The following is a description of a gene set: from publication Yevshin I, Sharipov R, Kolmykov S, Kondrakhin Y, Kolpakov F (PMID 30445619) studied in species Mus musculus Mouse Gene Set: ZFP986_UNIPROT_L7MUC9_UNREVIEWED_TARGET_GENES, and this is the list of marker genes: Atp6v0a1, Or6n1, Ncor1, Ctbp2, Slc38a8, Rnf115, Gm11637, Myo15a, Cltc, Gm15895, Alg11, Dnajc11, Ppp4r1, Gm12608, Fh1, Ercc2, Dync1h1, Gm2990, Fuca1, 2900079G21Rik, Niban3, Fam81a, Gm19705, Kcnj16 (NCBI Gene Id 338361), Ccdc14, Prpf38b, Gstp2, Krtap20-2, Tbl3, Gm26049, Inpp5k, Serpine2, Emc8, Myom3 (NCBI Gene Id 433768), Fam193b, Slc18a3, Gm11444, Ufsp2, Erg, Nvl, Aste1, Rph3a, Gm26795, Crem, Or2c1, Prickle4 (NCBI Gene Id 381104), Nt5el, Ruvbl1, 2310009B15Rik, Myh13, Mylpf, Bex6, Celf1, Synrg (synergin, gamma), Baz1b, Tm4sf5, Gm15039, Gm19261, Lat2, Tpd52l2, Prkag2, Gm16342, Agap3, Tram1, Acad11, Ddx52, Ccndbp1, Dlk1 (NCBI Gene Id 13386), Mdn1, Abca16, Gm30292, Recql5, Gm14210, Gm24068, Clec2d, Eva1b, Mgst2, Eif4e, Gm8849, Surf6, Gm26447, Il23a, Cep95, Rtl5 (retrotransposon Gag like 5), 4930447F24Rik, Luc7l3, Wdfy3, Faiml, Pde4dip, Vamp1, Tmed2, Ift122, Il2ra, Suv39h1, Gm24461, Carhsp1, Atf7ip, Ralbp1, Zdhhc15, Adgrb3, Gm14987, 4933408N05Rik, Capn10, Plcd4, Ifrd1, Smtn, Ntpcr, Sun1, Cngb3, Lrsam1 (NCBI Gene Id 227738), Rcan2, Mir411, Arl2bp (NCBI Gene Id 76171), Tigd4, Lztr1 (NCBI Gene Id 66863), Meg3, Grin3b, Limk2, Mir376c, Kif2c, Kdm5c, Nr6a1os, Rexo2, Acat1, Mzf1, Slc43a1, Cep85 (NCBI Gene Id 70012, centrosomal protein 85), 1110028F18Rik, Spcs1, Map2k1, Gm9599 (predicted gene 9599), Csf1r, Altre, Fhip2b, Rps12-ps7, 2810407A14Rik, Tmem242, Fam171b, Mir7675, Ly6g6f, Gtf2h2, Eif3d (eukaryotic translation initiation factor 3, subunit D), Snora81, Gm15610, Recql, Gm12654, Gm12740, Ttyh2, Scn9a, Cib1, Fam169b, Ube2f, Pick1, Mcf2l, Rnaseh2a, Dpep3, H2-M5, Nhsl2, Ppp4r4, Gm43772, Gstt3, Gm16096, Amz1, Ptges3, Mpi, Dnajb2, Atosb, Ddx23, Sox4, Alas1, Gm12886, Polr3f, Slc39a2, Zeb1os1, Cd9, Zfp661, Zfat, Eif4a2, Gm25489, Mroh1, Ltbp3, Gm15328, Adat1, Gripap1, Adar, Ddx60, Dhx9, Bmal1, Gm12333, 5930420M18Rik, Runx2, Mtfr1, Setdb2, Gm4847, Gm11379, Lhfpl4, Kcnh8, Uba2, Sec16a (NCBI Gene Id 99224), Gnpat, Radx, Aspscr1, Adamts2, Mettl13, Cxxc1, Klf8, Olig3 (oligodendrocyte transcription factor 3), Rragc, Vps72, Zmat1, Rfx2, Gm24878, C030013C21Rik, Bcar3, Zfp512b, Mdk, Gak, Borcs5, Dhx30, Vac14, Degs2, Foxp1, Ppp1cb, Col9a3, Gm12189, Trpm1, Arpp21, Prss54, 9330162B11Rik, Phex, Taco1, Klhl22, Gm25184